The following is a description of a gene set: Homology directed repair (HDR) through single strand annealing (SSA), similar to HDR through homologous recombination repair (HRR), involves extensive resection of DNA double-strand break ends (DSBs), preceded by ATM activation and formation of the so-called ionizing radiation induced foci (IRIF) at DNA DSB sites. Following ATM activation and foci formation, the two-step resection is initiated by the MRN complex (MRE11A:RAD50:NBN) and RBBP8 (CtIP) associated with BRCA1:BARD1, and completed by EXO1 or DNA2 in cooperation with DNA helicases BLM, WRN and BRIP1 (BACH1). Long 3'-ssDNA overhangs produced by extensive resection are coated by the RPA heterotrimer (RPA1:RPA2:RPA3), triggering ATR signaling. ATR signaling is needed for SSA, probably because of the related phosphorylation of RPA2.<p>RAD52 is the key mediator of SSA. Activated ATM phosphorylates and activates ABL1, and activated ABL1 subsequently phosphorylates pre-formed RAD52 heptameric rings, increasing their affinity for ssDNA. Phosphorylated RAD52 binds phosphorylated RPA heterotrimers on 3'-ssDNA overhangs at resected DNA DSBs. RAD52 also binds RAD51 and prevents formation of invasive RAD51 nucleofilaments involved in HRR.<p>RAD52 promotes annealing of two 3'-ssDNA overhangs when highly homologous directed repeats are present in both 3'-ssDNA overhangs. Nonhomologous regions lying 3' to the annealed repeats are displaced as 3'-flaps. The endonuclease complex composed of ERCC1 and ERCC4 (XPF) is subsequently recruited to SSA sites through direct interaction between RAD52 and ERCC4, leading to cleavage of 3' flaps. The identity of a DNA ligase that closes the remaining single strand nicks (SSBs) to complete SSA-mediated repair is not known.<p>SSA results in deletion of one of the annealed repeats and the intervening DNA sequence between the two annealed repeats and is thus mutagenic. part of: HDR through Homologous Recombination (HRR) or Single Strand Annealing (SSA) Reactome Pathway: HDR through Single Strand Annealing (SSA) studied in species Homo sapiens, and this is the list of marker genes: ATR, RAD9A, RAD1, BRCA1, TOPBP1, ERCC4 (NCBI Gene Id 7509), RFC4, TOP3A, DNA2, RPA3, NBN, RMI2, LIG1, RMI1, RAD50, RBBP8, RAD9B, RFC5, WRN, RFC3, RAD17, MRE11, KAT5, RHNO1, HUS1, RPA2, ATRIP, ERCC1, BARD1, BLM, EXO1, RAD52, BRIP1, RFC2, ABL1, RAD51, ATM, RPA1